The following is a description of a gene set: Human Gene Set: GSE3982_MEMORY_CD4_TCELL_VS_BCELL_DN In the present study we used Affymetrix oligonucleotide microarrays to produce gene transcription profiles for the major leukocyte types in humans. This comprehensive dataset enabled us to not only establish which genes were expressed in each leukocyte type, but also which genes were expressed in each subset after activation. The used of a comprehensive dataset of gene profiles from all the major human leukocyte subsets enabled a novel and powerful means for identification of genes associated with single leukocyte subsets, or different immune paradigms. studied in species Homo sapiens Genes down-regulated in comparison of memory CD4 T cells versus B cells. from publication Jeffrey KL, Brummer T, Rolph MS, Liu SM, Callejas NA, Grumont RJ, Gillieron C, Mackay F, Grey S, Camps M, Rommel C, Gerondakis SD, Mackay CR (PMID 16474395), and this is the list of marker genes: ZDHHC14, WARS1, CHFR, KIAA0040, H2AC6, SLC15A3, ING1, MAPK12, CD79B (NCBI Gene Id 974), UBE2J1, IRAK1 (NCBI Gene Id 3654), LAMP5 (lysosomal associated membrane protein family member 5), GUSBP11, SLC15A2 (NCBI Gene Id 6565), SPIB, HESX1, IGKC, RUFY1, HLA-DOB, REXO4, TCF4, SERPINF1, E2F5, COQ2, CD72, SIDT2, TRAK1, LAT2, NADK, ZNF106, TLE1, ISG20, CLEC4A, PAX5, UROD, BACH2, SIDT1, TOR3A, RAB31, COBLL1 (cordon-bleu WH2 repeat protein like 1), IL4R, COX17, SCN3A, HLA-DMB, ZNF165, HLA-DMA, DGKD, CD1D, SIPA1L3, KCNN4, SAV1, PSEN2, OPN3, SWAP70, SYPL1, IRF4 (interferon regulatory factor 4), BHLHE41, NUMB, OSBPL10, MRPL15, HS3ST1, SCPEP1, TMEM243, TNFRSF17, CA2, PIP5K1B, SHMT2, TMT1A, LYN, TFEB (NCBI Gene Id 7942), DLAT (dihydrolipoamide S-acetyltransferase), SQLE, IGHA1, IRF8, TMUB2, TMEM14B, MZB1, YBX3, GSN, OAS1, CD180, PECAM1, CD200, MCM5, EIF2B1, HLA-DQB1, IGKV1D-13, ARHGEF7, MICAL3, FCER2, IL13RA1, RHOB (ras homolog family member B), EAF2, BASP1, TMEM70, NASP, S100A8, TBC1D9, PTPN6, CDK14, GABARAP, AGPAT5, BCL11A, C5orf15, SCO2, CTNNA1, ZNF318, PAPSS1, MEF2C, SEL1L3, SLC37A1, RASGRP3, CD74, CD38, IGHM, ERCC1, STAP1, CTSH, PKIG (cAMP-dependent protein kinase inhibitor gamma), LMO2, LY86, BANK1, IGHD, SYK, JCHAIN, PDLIM1, ZNF232, TERF2, COL9A3, HPS5, EIF2AK3 (eukaryotic translation initiation factor 2 alpha kinase 3), PSMB6, POU2AF1, ADO, ADD1, H2BC9, BMP2K, ALDH2, MED14, USP22, PTK2B, SP110, CCNB1IP1, LYST, PARM1, GNG7, ACP5, SNRNP25, CEPT1, IGKV4-1, TMEM62, MICALL1, CCT2, EMC8, MRPL40, PARP1, JUN, CAT, GNA12, NT5E, MS4A1, FAM30A, BTN2A2, CKAP4, TMEM156, ALOX5, SEC23B, BLNK, TLR7, ORC5, XIST, GM2A, H2BC12 (H2B clustered histone 12), FCGR2C, P2RX1 (purinergic receptor P2X 1), CSNK2A1, PUS1, STX7, P2RX5, TSPAN13, IGLL3P, QRSL1, MAP4K2, ITPR1, COX15 (cytochrome c oxidase assembly homolog COX15), ADK, ZBTB5, CYBB, RUBCN, HHEX, PLCG2, RABGEF1, DUS2, CACNA1A, HSD17B4, ARHGAP17, TSPAN3